The following is a description of a gene set: Reactome Pathway: Presynaptic phase of homologous DNA pairing and strand exchange electronically inferred by orthology from the curated human pathway This event has been computationally inferred from an event that has been demonstrated in another species.<p>The inference is based on the homology mapping from PANTHER. Briefly, reactions for which all involved PhysicalEntities (in input, output and catalyst) have a mapped orthologue/paralogue (for complexes at least 75% of components must have a mapping) are inferred to the other species. species: Mus musculus part of: Homologous DNA Pairing and Strand Exchange, and this is the list of marker genes: Brca1, Top3a, Brca2, Rad51b, Blm, Rad51c, Dna2 (NCBI Gene Id 327762), Mre11a, Kat5, Rbbp8, Wrn, Nbn, Bard1